Given this list of marker genes TMEM39A (NCBI Gene Id 55254), TESC, GPR160, MAGT1, HTATIP2, SPCS1, IP6K1, SSR2, FILIP1, LMAN1, CHRNB4, RRBP1, PRRC1, LARP1B, OSTC, NANS, HSPA13, RPN1, SURF4, QPCTL, NBAS, SLC30A7 (solute carrier family 30 member 7), IGHA2, BPGM, HDLBP, DNAJB9, CRELD2, SEC11C, EBP, CD28, BET1, TMED2, MANF, BHLHA15, NTAQ1, TENT5C, DERL1, CTSB, PGAM2, STT3A, IGKC, SPCS3, M6PR, SLC44A1, TRAM2, CCDC47, MGAT2, TMEM248, DDOST, ARMCX3, SGPP2, SCFD2, UBXN4, GPR89A (NCBI Gene Id 653519), here is a description of the gene set: from publication Mori S, Rempel RE, Chang JT, Yao G, Lagoo AS, Potti A, Bild A, Nevins JR (PMID 18922927) The Emu-myc transgenic mouse has provided a valuable model for the study of B-cell lymphoma. Making use of gene expression analysis and, in particular, expression signatures of cell signaling pathway activation, we now show that several forms of B lymphoma can be identified in the Emu-myc mice associated with time of tumor onset. Furthermore, one form of Emu-myc tumor with pre-B character is shown to resemble human Burkitt lymphoma, whereas others exhibit more differentiated B-cell characteristics and show similarity with human diffuse large B-cell lymphoma in the pattern of gene expression, as well as oncogenic pathway activation. Importantly, we show that signatures of oncogenic pathway activity provide further dissection of the spectrum of diffuse large B-cell lymphoma, identifying a subset of patients who have very poor prognosis and could benefit from more aggressive or novel therapeutic strategies. Taken together, these studies provide insight into the complexity of the oncogenic process and a novel strategy for dissecting the heterogeneity of B lymphoma. Up-regulated genes in the B lymphocyte developmental signature, based on expression profiling of lymphomas from the Emu-myc transgenic mice: plasma cell. Human Gene Set: MORI_PLASMA_CELL_UP species: Mus musculus